Given this list of marker genes Prps1l1, Pygl, Prps1, Prps2, Prpsap1, Prpsap2, Prps1l3, here is a description of the gene set: Mouse Gene Set: GOBP_5_PHOSPHORIBOSE_1_DIPHOSPHATE_METABOLIC_PROCESS species: Mus musculus The chemical reactions and pathways involving 5-phosphoribose 1-diphosphate, also known as 5-phosphoribosyl-1-pyrophosphate.